Given this list of marker genes KMT2D, GNB2, LBR, PIGY (NCBI Gene Id 84992), ZNF699, here is a description of the gene set: Human Gene Set: HP_ECHOGENIC_FETAL_BOWEL studied in species Homo sapiens Echogenic bowel is defined as fetal bowel with homogenous areas of echogenicity that are equal to or greater than that of surrounding bone. Echogenic fetal bowel